Given this list of marker genes MX1, VAMP3, NIP7, H2BC12, LRRN3, ZNF362, ATF3, PLA2G2F, RNF125, CSRNP2, KAT8, CFHR5, UBE2A, ADAR, EMX2, FBXW7, MRPL20, KLRB1, CROCCP2, NBL1 (NCBI Gene Id 4681), MKNK2, HSPA4, SNN, HYMAI, KMT2A, BAK1, ZNF131, ABCC10, LSS, SCLY, CYP3A5, MYEF2, DICER1, GAPVD1, FAM174C, H2BC8, CD160, AKAP13, S100B, MAEA, TMEM187, MYL5, HELLS, AP1S1, MAX, RBL2, P2RX5, SLAMF8, DNAJB14, HSPBAP1, GATA3, OAS1, AGFG2, KATNBL1, RPS18, PI4KB, VWA8, SESN1, AMOTL2, GUSBP14, PIGG, TRAF3, TRMT12, PLCG2, ZMAT3, UBE3C, AUTS2, KIT, TMA7, IL18RAP, ARHGEF18 (Rho/Rac guanine nucleotide exchange factor 18), SIKE1, KBTBD4, KANK1, TRDN, SENP3, PTH2R, NCAM1, MAPK13, SNX27, TTLL4, SLC35A3, DDX6, SERTAD2, LPP, DNMT3B (NCBI Gene Id 1789), ZKSCAN7, UBAC1, CHST2, ABCF1, EXO5 (NCBI Gene Id 64789), GOLGB1, TMX2, PYHIN1, YWHAB, EIF1, RRAGB, MORC2, AP3D1, SOX30, RIOK3, EFHC1, BIRC3, FBXO2 (NCBI Gene Id 4930), CYFIP2, ZNF226, CDKN1A, TPH1, SMPD3, TOGARAM1, ING3, ZNF696, SOS1, XPC, MAP9, CSTB, LAIR1, TRIM68, SMURF1, IL17RA, PRDM4, PITPNA, ZSCAN12, JADE1, LINC00588, MZF1, KHSRP, STOML1 (NCBI Gene Id 9399), TM7SF3, WNK1, STXBP1, F11R, GNL3LP1, ZNF257, SNX16, MTF1, TMT1A, RNASE6, MTDH, EGR3, TRIM38, MAPK1IP1L, IKBKE, MYO1F, DUS4L, DSPP, SIMC1P1, FBXW4, HSD17B7 (NCBI Gene Id 63064), NOD2, FHL1, EVI5, RPLP2, POGZ, AFDN, LAT2, TRIM32, ZMYND8, SLC35D2, HNRNPL, PGAP6, NBR2, GUSBP3 (NCBI Gene Id 653188), TMPRSS3, NKTR, YY1AP1, RPS28, PRF1, YJU2B (YJU2 splicing factor homolog B), IPCEF1, ITM2C, ZNF407, RPS29, PDGFD, ZNF91, CHST8, CAPRIN2, IPO9, STOM, ZNF623, POLR1E, AK2, NRN1, FN1, CSNK1G1, PIK3R3, SCCPDH (saccharopine dehydrogenase (putative)), SLC46A3, PPM1H, SLC16A6, KIR2DS2, IFI6 (interferon alpha inducible protein 6), CNDP2, PAFAH2, TXLNGY, TTBK2, XAF1, NOP2, PTP4A2, TRAF3IP3, here is a description of the gene set: Human Gene Set: GSE35435_RESTING_VS_IL4_TREATED_MACROPHAGE_UP Analysis of alternative activation of macrophages at gene expression level. The study forms part of a wider study where we compare the effects of IL-4 in different human and mouse macrophages. Our results support the notion that in vitro culture conditions greatly affect the macrophage response to IL-4. Total RNA obtained from bone marrow derived macrophages upon exposure to 20 ng/ml of IL-4 for 18 hours. Genes up-regulated in macrophages: resting versus stimulated by IL4. species: Homo sapiens from publication Martinez FO, Helming L, Milde R, Varin A, Melgert BN, Draijer C, Thomas B, Fabbri M, Crawshaw A, Ho LP, Ten Hacken NH, Cobos Jiménez V, Kootstra NA, Hamann J, Greaves DR, Locati M, Mantovani A, Gordon S (PMID 23293084)